The following is a description of a gene set: Mouse Gene Set: DZIP3_TARGET_GENES Genes containing one or more binding sites for (Dzip3) in their promoter regions (TSS -1000,+100 bp) as identified by GTRD version 20.06 ChIP-seq harmonization. studied in species Mus musculus from publication Yevshin I, Sharipov R, Kolmykov S, Kondrakhin Y, Kolpakov F (PMID 30445619), and this is the list of marker genes: mt-Cytb, 1700086P04Rik, Rnf19b, Ccz1, mt-Tt, mt-Nd6, Tdpoz4 (NCBI Gene Id 677624), Nadk, mt-Te, Gm22107, Meaf6, Por (cytochrome p450 oxidoreductase)